The following is a description of a gene set: 3-Methylglutaconic aciduria Human Gene Set: HP_3_METHYLGLUTACONIC_ACIDURIA species: Homo sapiens An increased amount of 3-methylglutaconic acid in the urine., and this is the list of marker genes: TMEM70, MT-ATP6, POLG, ATP5MK, ATP5F1E, SERAC1, DNAJC19, LETM1, ATAD3A, CLPB, SDHA, AUH, TAFAZZIN, MT-TL1, HTRA2, ATP5F1A, NGLY1, ATP5F1D, TIMM50, FBXL4, ATPAF2, MT-ATP8, OPA3, FDX2, MICOS13, AGK, SUCLG1